The following is a description of a gene set: Common Pathway of Fibrin Clot Formation studied in species Mus musculus Mouse Gene Set: REACTOME_COMMON_PATHWAY_OF_FIBRIN_CLOT_FORMATION, and this is the list of marker genes: Procr, Cd177, Serpinc1, Fgb, Serpina5, Fgg, F13a1, F13b (NCBI Gene Id 14060), F8, F2, Thbd, F2r, Pf4, Fga, F10, Serpind1, Proc, Serpine2, Prtn3, Pros1, F5